Given this list of marker genes CACNA1I, CCL3, P2RX5, WNK3, NALF1, TRPM1, TRPV4, CACNA1S, PPP3CA, TRIM27, ATP2C2, SLC8A1, LGALS3, CACNA1D, TRPC4, PPP3R1, SLC30A1, CACNB2, SLC24A5, STRIT1 (small transmembrane regulator of ion transport 1), TRPV2, PLN, GRM6, PPP3R2, SLC24A4, CACNA1C, P2RX1, CDK5, EGF, CRH, MIR200C, CAV3, SLC8A3, UCN, FYN, ITPRIPL1, MIR208B, EPPIN, FCRL3, CTNNB1, GCG, HES1, CASR, ATP2A1, SELENON, SPINK1, MCUR1, PRNP, CACNA1E, AKAP5, CALHM2, TRPV6, CACNA1F, TRPV5, CACNA1A, MIR34A, GCK, NALF2, KCNN4, TRPV3, TRPM2, SLC24A2, CACNA1B, TRPV1 (transient receptor potential cation channel subfamily V member 1), MS4A1, PDGFRB (platelet derived growth factor receptor beta), CXCL12, MICU1, CASK, SEMG1, MIR208A, ORAI1, HOMER1, SLC24A1 (solute carrier family 24 member 1), CCL2, PPP3CB, STC1, PDGFB, DDIT3, ISL1, CACNA2D1, PPP3CC, SLC8A2, PKD2, SLN, PLPP4 (phospholipid phosphatase 4), ATP2B4, CACNA1G, CACNA1H, here is a description of the gene set: species: Homo sapiens Human Gene Set: GOBP_CALCIUM_ION_IMPORT The directed movement of calcium ions into a cell or organelle.